The following is a description of a gene set: species: Homo sapiens Genes down-regulated in CD8A- splenic dendritic cells: wildtype versus IFNB1 knockout mice. Human Gene Set: GSE12392_WT_VS_IFNB_KO_CD8A_NEG_SPLEEN_DC_DN from publication Zietara N, Łyszkiewicz M, Gekara N, Puchałka J, Dos Santos VA, Hunt CR, Pandita TK, Lienenklaus S, Weiss S (PMID 19581626) Type I Interferons encompasses a large family of closely related cytokines comprising of at least 13 IFN-α isotypes and single IFN-β. Both IFN-α and IFN-β exert their activity through a common receptor IFNAR. Type I Interferons have broad regulatory effects and various subtypes of dendritic cells are influenced by this cytokines. In our study we asked question whether the low, constitutive levels of type I Interferons produced under steady state conditions are important for proper function of splenic conventional dendritic cells., and this is the list of marker genes: ANKH, RNF130, CNTRL, MPC1, DIAPH1, ELK3 (ETS transcription factor ELK3), DGKD, AKAP10, APPL2, SLC15A4, RUNDC3B, MYO1E, GPM6B, KMT2D, TXNIP, PIK3R6, RAC2, MYO1F, JAK3, NR1D2, CLPTM1, RAPGEF1, PNPO, SLCO5A1, HSD17B4, SLC16A7, SSH2, NXPE4, DBP, CYRIA, CHD6, TMEM141, DACT3, CR2, L1CAM, AKAP13, CSF1R, ST3GAL2, BACH1, GRPR, STAP1, NDST1, CLN8, DEGS1, RTF1, MAP3K5, ZNF81, AQR, HLA-DOA, CD300LB, MTFR1L, GSTK1, ANKRD50, WNK1, B3GNT6, PANX1, TMEM131L, HELZ2, BICRAL, CASP1, SBNO1, XIAP, OSBPL8 (NCBI Gene Id 57601), LTA4H, MYCBP2, RNF43, TAF9B, CD244 (CD244 molecule), SPIRE1, S100PBP, USB1, MBIP, PAOX, NEURL2, ARL6IP5, GGH (NCBI Gene Id 8836), PDCD1LG2, SESN2, EIF5A2, FCRL1, B4GALNT1, HLX, IFT140, TEX9, SETD6, TBC1D4, HACD4, RALGDS, EEF2K, CD53, VOPP1, PAG1, ELMO2, B4GALT6, VAMP4, GRAP, IFIT1, LCP2, RGS12, RBM38, JAK2, TEC (NCBI Gene Id 7006), NAPG, WDR5B, SIMC1, APBB1IP, NFAT5, SLC6A13, B3GNT8 (NCBI Gene Id 374907), SLC44A1, IFI30, RGS3, PIK3CG, CD47, ARAP2, PDE4DIP, RMND5B, SESN1, NIPA2, FAM13B, NFKBIE (NCBI Gene Id 4794), GPR155, CDKN2B, RSAD2, PIGV, TRMT112, CDH17, B4GALT3, SORL1, CDCP1, CDC42EP2, NLRP10, HSH2D, MMP9, USP18, ACE, ASB2, CRLF3, S100A10, WLS, ABCB1, PTPRJ, DSCAM, PTP4A2, IL31RA, CDK17, LY9, TRPS1, MRPL33, GLUD1, NAPSA, GPR183, ACOT7, ENTPD4, SNX30, CHKA, PLAUR, FILIP1L, RAP1A, ITGB3, STK4, SULF2, PTK2, MEGF9, RBM43, ZNF574, JMJD1C, BMP2, IL21R, ESCO1, PYGL, CNOT6L, MDP1, IGSF6, CHD9 (NCBI Gene Id 80205), PRPS2, IFI27L2 (NCBI Gene Id 83982), MSN, MKRN1, PTPN12, PRKCB, RAB24, ABCA7 (NCBI Gene Id 82843), OAS2, PHTF2, MAP2K1, KIAA0930, KLHDC1, BCL3, PTPN3, CMIP, IL7R, BCAS1, TMEM168, DAPP1, PGLYRP1, S100A6, SIGLEC10, RAB37, SLC44A2